The following is a description of a gene set: Mouse Gene Set: GOBP_REGULATION_OF_ANTIBACTERIAL_PEPTIDE_PRODUCTION species: Mus musculus Any process that modulates the frequency, rate, or extent of antibacterial peptide production., and this is the list of marker genes: Ppl, Klk7, Klk5, Pgc, Evpl (envoplakin), Ivl, Nod2